The following is a description of a gene set: Abnormality of the lower urinary tract species: Homo sapiens Human Gene Set: HP_ABNORMALITY_OF_THE_LOWER_URINARY_TRACT An abnormality of the lower urinary tract., and this is the list of marker genes: REEP1, POLR3A, RERE, FGD1, HNRNPA1, MAPT, VPS35L, TPP1, MARS2, AQP2, WDR62, GP1BB, CILK1, TMEM216, RTTN, MECP2, POLRMT, BNC2, EHMT1, TCTN3, HNRNPK, PAICS, RLIM, ARID1B, TYROBP, PEX11B, LMNA, NDUFA8, ORC1, CLCNKB, COG7, HOXD13, FOCAD, HOXA13, WDPCP (NCBI Gene Id 51057), RYR1, SOX4, FANCB, CC2D2A, DSE, BUD23, PIGQ, SLC1A4, DPYSL5, HNRNPU, KIF1A, TRAPPC10, NCF1, GPC3, COLEC10, SIX1, RNF170, IFT27, TTR, SF3B2, CTC1, ARL6, BAZ1B, SPEN, UBR1, CIT (citron rho-interacting serine/threonine kinase), SPAST, ROBO2, JRK, GABRA1, TBCK, KMT2D, NIPA1, MED12L, CTSH, SNCA, TMEM237, NHP2, GABRA3, TBX22, IGHMBP2, AFF4, PEX16, SDCCAG8, KMT2B, UMOD, GLI1, BRIP1, TCTN1, ATXN8OS, MYCN, RBCK1, RTN2, HNRNPH1, DYNC2I1, EFEMP1, GATA1, RIN2, MTMR14 (myotubularin related protein 14), PIK3CA, DNMT3A, KDM3B, RASA1, FANCI, DSTYK, TFAP2A, RAF1, SLC5A2, HBA2, GBA2, PSMD12, PIGN, KCNJ10, SPART, UBAP1, SP110, PINK1, AKT1, COL5A1, GATA3, CDC42, MYL9, SLC35A2, FBLN5, GABRG2, PITX2, H19, FGFR2, HMGA2, GTF2IRD2, TXNDC15, UNC45A, NCAPD3, HPSE2, SYNGAP1, EXT1, NEXMIF, KCNAB2, SRD5A2, COMT, RNU12, MYF6, GJC2, PKP1, EVC2, FREM2, ZFX, EXT2, COPB1, SLC44A1, ZIC3, TUBB, VANGL1, ARNT2, NEB, JAG1, PLXNA1, BBS12, TTI1, PDE4D, SMAD3, USP9X, GABRB3 (gamma-aminobutyric acid type A receptor subunit beta3), NCAPG2, WNT5A, HDAC8, LIG4, NUP37, TRPS1, KPNA3, COQ2, ATXN3, DKK1 (dickkopf WNT signaling pathway inhibitor 1), ANKLE2, VPS35, DPH2, WNT7B, RARB, VANGL2, RPL18, SIX5 (SIX homeobox 5), ACTA1, TMEM231, CYP17A1, HAAO, SRY, KCNC3 (NCBI Gene Id 57363), SYNE1, GBA1, SIAH1, WWOX, COG1, FLT4, HOGA1, RPGRIP1L, PEX6, SEMA3E, RPL9, NRIP1, SMG8, FXN, RPS17 (NCBI Gene Id 6218), ATR, GPC4, VAMP7 (NCBI Gene Id 6845), CEP135, MAX, CUX1, NDUFA6, MNX1, FGFR3, UPB1, MAD2L2, IGF2, SLC12A3, CLCN6 (NCBI Gene Id 1185), GTF2I, GAA, FIG4, CDC42BPB, PEX2, SDHD, NPHP1, NFIA, CENPE, CACNA1G, NKX2-1, AVPR2, GREB1L, PAH, KAT6B, SMO, CLIP2, FANCE, IFT74 (NCBI Gene Id 80173), BBS2, HPDL, ERCC4, ENSG00000288330, GATAD2B, MMP23B (matrix metallopeptidase 23B), SPTLC1, SMAD4, MKKS, CDK5RAP2, KNL1, CHCHD10 (coiled-coil-helix-coiled-coil-helix domain containing 10), MAPRE2, HLA-DRB1, SKI, TAF13, STAT6, BICC1, SLC2A1, FANCA, ZFPM2, SCLT1, PRKACB, GBE1, TRIM28, CDCA7, MAP3K1, SCN9A, GIGYF2, DBH, TTC8, DYNC2H1, EFNB1, TP63, RAD51, PDGFB, ADNP, RPS15A, BBS5, ATP13A2, CCL2, CHD4, BBS1, MAB21L1, KCND3, SOX9, MLXIPL, AR, LIG3, SMARCE1, KY, STX1A, POR, ASXL1, PSAP, VCP, PRKCZ (protein kinase C zeta), NDUFB7, ATXN10, LMOD3, PRKACA, VPS37D, ZMYM2, STRA6, ALS2, NSD2, SBF1, ELN, PRDM16, HTRA1, RFWD3, PEX14, BICRA, PEX13, DHCR7, TMEM63A, METTL27, NPM1, PSMB10, KDM5B, CCDC22, MTFMT, SAMD9, SDHAF1, STAR, SALL1, HBA1, PUF60, MID1, PIGO, PHC1, DHX37, METTL5, SOX17, TMEM67 (transmembrane protein 67), EN1, VPS11, HUWE1, DDHD2, COLEC11, TMEM94, NOP10 (NCBI Gene Id 55505), KCNT1, MYH3, UBE2A, CPLX1, CDKN1C, BAP1, VPS13C, FBXO7, PALB2, KDM6A, NDUFB11, GALC, H4C11, MYLK, POLG (DNA polymerase gamma, catalytic subunit), SMARCB1, RPS28, SIX6, AMFR, CCNQ, GMNN, ROBO1, FZD2, BUB1B, MAPKAPK5, RPS26, WARS1, FRAS1, PAK2, EIF4G1, EVC, CDK6, RSRC1, STAMBP, TERT, RNF125, GRIP1, RPL10, AIP, POLA1, DEPDC5, GFAP, KAT5 (NCBI Gene Id 10524), CHMP2B, RAP1B, MCM7, RAD51C, ZC4H2, PANK2, ATXN1, TRIP13, GJA1, POLE (DNA polymerase epsilon, catalytic subunit), MESP2, UBE2T, ARSA, SEC24C, B4GALNT1, CHRNG, SMC3, ISL1, ATL1 (NCBI Gene Id 6681), PLEC, CHD7, FANCC, PLA2G6, ITGA6, ADH1C (alcohol dehydrogenase 1C (class I), gamma polypeptide, NCBI Gene Id 126), DMPK, ARID1A, CDC45 (NCBI Gene Id 8319), CUL4B, RPL26, ABL1, PIEZO2, RSPO1, DNMT1, STUB1, WFS1, PQBP1, DLL3, SOX2, MYO1H, APC2, TRIM8, CCND1, AP5Z1, SIGMAR1, LMNB1, RPGRIP1, ZNF365, NELFA, FAM20A, PI4KA, SLC25A13, ABCD1, RPL35A, OTUD5, ATP7A (ATPase copper transporting alpha), SOX11, LSS, AUH, GNB1, BMP1, ERCC8, TWNK, LMOD1, DNM2, TBXT (T-box transcription factor T), CRH, FANCL, B9D2, NSUN2, PPP3CA, BRD4, RPL27, RPL8, SMARCA4 (NCBI Gene Id 6597), CYP11A1, TNXB, SASS6, FOXP2, PDGFRB, TAF6, TAPT1, PNPLA6, OBSL1, ORC6, UFD1 (ubiquitin recognition factor in ER associated degradation 1), COL1A1, PRMT7, MYOCD, BRCA2, POLG2, NAB2, SMARCA2, SLC9A6, CFAP43, CCBE1, RETREG1, ELOVL1, PRKAR1B, ROR2, KIF5A, SCUBE3, REEP2, CHRNA3, BRAF, SPTBN1 (spectrin beta, non-erythrocytic 1), PARN, PEX1, ZMPSTE24, FOXC1, COX7B, DYSF, LFNG, CEP63, SUCLG1, PAX2, ERCC6, TONSL, NDUFS4, MAPKBP1, RPS27, SSR4, SETBP1, ARX, LIMK1, FBXL4, UBE4B, SMS, MKS1, BRCA1 (BRCA1 DNA repair associated), SPOP (NCBI Gene Id 8405), DPF2, MYH11, PEX10, TRIO, PEX12, ZMIZ1, LRRK2, COL5A2, FA2H, SIN3A, XRCC2, CEP19, GABRD, CHRNB2, CHRNA4, ATRX, GALNT2, RNF168, VAC14, PIGG, LTBP4 (NCBI Gene Id 8425), RPL35, KCNQ1OT1, GTF2IRD1, NOTCH2, HS6ST2, LRIG2, GGT1, TMEM107, DKC1, TRAPPC12, UFC1, ESCO2, LAMB3 (laminin subunit beta 3), CLMP (NCBI Gene Id 79827), ERLIN2, FUS, MED12, PBX1, ALG9 (ALG9 alpha-1,2-mannosyltransferase), DCHS1, WNT3, MCPH1, MYMK (myomaker, myoblast fusion factor), B9D1, TERC, KDM1A, HLA-B, CYB5A, WBP4, RPS29, PPP1R12A, FDFT1 (farnesyl-diphosphate farnesyltransferase 1), MAP2K1, DDX6, MFSD2A, CEP85L, FLNA (NCBI Gene Id 8272), RALGAPA1, FARS2, LZTFL1, DLG3, KIAA0586, OGT, PEX19, BBS10, ACTG2, CYP21A2 (NCBI Gene Id 1589), PIK3R5, TRRAP, THOC6, MORC2, REST, EPG5, CEP290, SQSTM1, CAMK2B, CDT1, SPG7, APRT, SPG11, ZFYVE26, GNB2, PEX3, ARVCF, PLD1, TBP, EIF2AK1, KLF1, ASPM, GRB10, HSD17B3, NF2, USB1, HSD17B10, TBCD, ACBD6 (NCBI Gene Id 84320), FRMD5, POT1, KCNJ18, CDH11, DNAJC30, CASZ1, EP300, ATXN2, CDC6, TCF12, NBN, SLC25A4, G6PC3, H4C9, HYLS1, BIN1, SLC25A10, MED27, IFT80, FGF10, LETM1, KLHL41, COPB2, SMCHD1, ITGB4, MMP1, HSPG2, SUFU, STIL, FANCM, SNCAIP, WT1, ADA2, KIAA0753, RAC2, SH2B1, NPHP3, ZMYM3 (NCBI Gene Id 9203), FLVCR1, KLHL40, IKZF1, NOTCH3, PLP1, WNT7A, FOXF1, NEFL, TTPA (NCBI Gene Id 7274), CARMIL2, BPTF, MCTP2, GPR101, BBIP1, NDUFB8, PMP22 (NCBI Gene Id 5376), PTPRF, SMARCC2, DIS3L2, HEXB, CUL7, HLA-DQB1, GNA11, SMARCD1, SLC31A1, ARL6IP6, DCDC2, PRPS1, WNT4, NR5A1, EYA1, COG5, ANKRD11, DVL1, DPH1, PRDM8, ACER3, FGFR1, TMEM70 (transmembrane protein 70), CREBBP, FITM2, SDHB, COL18A1, CABP4, KCNQ1, SDHA, TNFSF4, RPL11, CCDC8, DVL3 (dishevelled segment polarity protein 3), BBS9, NR0B1, LUZP1, PUM1 (pumilio RNA binding family member 1), CHST14, COL1A2, LAMA3, CFAP418, TCTN2, ALDH18A1, HIRA, DARS2, ARID2, PPOX, MBTPS2, CHRM3, PYCR2, C2CD3, PLOD1, FAT4, HCCS, TRAF7, RPL15, MYMX, FANCG, TINF2, NAA10, GLI3, RAC1, IFT57, KIF14 (kinesin family member 14), GATA4, SETX, UBA1, EPHB4, ALG12, RREB1, FKBP14, SLX4, RIPPLY2, FANCD2, DNAJC13, CACNA1H, SARS1, MAMLD1 (NCBI Gene Id 653998), MOG, POU6F2, KIFBP, HCRT, CARS1, MTM1, CHRNA2, TRIM32, KANSL1, FMR1, FANCF, EFEMP2, SPRED1, RECQL4, TRAPPC14, HEATR3, CYP7B1, EIF4H, NIPBL (NIPBL cohesin loading factor), TRPV4, PAX6 (NCBI Gene Id 5080), TSR2, RBBP8, BBS4, RTEL1, TYMS, SALL4, SCAPER, TBL2, ERI1, NOTCH2NLC, RPL31, DNAJC19, DYNC2I2, SRCAP, PSPH, ALMS1, HSPA9, CACNA1S, PIGA, PTDSS1, PTPN11, B3GLCT, KMT2C, TMEM270, ZNF699, HNF1B, NSD1, HPS6, JMJD1C, RPL5, IFT172, MYRF, NR2F2, HSPD1, PRNP, WRAP53, RPS10, FOXP1, EBF3, RFC2, DPH5, PCNT, RBM8A, RPS19, EIF2AK2, HES7, SMC1A, ITPR1, ZEB2, STK11, HPRT1, TGFB1, P2RY11, FGFRL1, CISD2, ATP1A3, HSD3B2, PEX5, RPS20, LAMC2, MT-TT, DACT1, ERMARD, TBX1, CTBP1 (C-terminal binding protein 1), RPS24 (NCBI Gene Id 6229), MAP3K7, MTOR, CAPN1, SLC20A2, KRAS, SETD5 (SET domain containing 5), MAB21L2, BBS7, FERMT1, RRM2B, CSPP1, WDR35, DYNC2LI1, PLAG1, NGF, LTBP1, KIF7, CEP152, PNPT1 (NCBI Gene Id 87178), MED25, ORC4, PDPN, NR4A2, ARCN1, ATP6AP2, TIMM50, MPZ, MACF1, AGXT, BCOR, PEX26, ADAT3, SACS, FKBP6, WASHC5, DYRK1A, RPS7, HACE1, BDNF, RAD21, STAT1, COL7A1, FUZ, SHANK3, HMBS, COL3A1, LRPPRC (leucine rich pentatricopeptide repeat containing), DPP9, CPT1C, SKIC3 (SKI3 subunit of superkiller complex), HNRNPA2B1